Given this list of marker genes Psme2b, Ifi27l2a, Nt5c3, Trim30a, H2bc21, Znfx1, Ifitm3, Gtf2b, Shisa5, Isg15, Slfn8, Ifit2, Mndal, Dhx58, Oasl1, Irf7, Samhd1, Rsad2, Oas3, Herc6, Isg20, Serpina3g, Gbp2, Ifit3, Phf11a, Slfn2, Irgm1, Ifit1, Snhg9, Slfn5, Xaf1, Agrn, Ifi204, Zup1, Socs2, Selenow, Rtp4, Ifi207, Oasl2, 9930111J21Rik2, Ifi47, Cacfd1, Stat1, Rnf26, Cmpk2, Phf11d, Zbp1 (Z-DNA binding protein 1), Apobec1, Parp14, Rnf213, Trim30d (tripartite motif-containing 30D), Ogfr, Igtp, Irgm2, Usp18, Parp12, Dnal4, Lgals3bp (NCBI Gene Id 19039), Sp100, Bst2, Cxcl10, Sema4b, here is a description of the gene set: Mouse Gene Set: CUI_LANGERHANS_IFNA1_RESPONSE_UP from publication Cui A, Huang T, Li S, Ma A, Pérez JL, Sander C, Keskin DB, Wu CJ, Fraenkel E, Hacohen N (PMID 38057668) Genes positively differentially expressed in cell type: Langerhans upon treatment with cytokine: IFN-α1 in mouse lymph nodes in vivo. species: Mus musculus Cytokines mediate cell-cell communication in the immune system and represent important therapeutic targets. A myriad of studies have highlighted their central role in immune function, yet we lack a global view of the cellular responses of each immune cell type to each cytokine. To address this gap, the authors created the Immune Dictionary, a compendium of single-cell transcriptomic profiles of more than 17 immune cell types in response to each of 86 cytokines (>1,400 cytokine-cell type combinations) in mouse lymph nodes in vivo. A cytokine-centric view of the dictionary revealed that most cytokines induce highly cell-type-specific responses. For example, the inflammatory cytokine interleukin-1β induces distinct gene programmes in almost every cell type. A cell-type-centric view of the dictionary identified more than 66 cytokine-driven cellular polarization states across immune cell types, including previously uncharacterized states such as an interleukin-18-induced polyfunctional natural killer cell state.